Given this list of marker genes FUBP1 (far upstream element binding protein 1), KCNJ15, RSC1A1, SERPINA3, CCL4, GSR, ROR2, HSP90AB1 (heat shock protein 90 alpha family class B member 1, NCBI Gene Id 3326), CD38, LY6G6D, BTN3A3, CEP170B, KYAT1, ADAM19, BRSK2, ST3GAL5, VCAN, ANXA2, RPA3, EIF3B, CYP1B1, SOCS6, ALAS1, B3GNT2, CD14, PBX2 (PBX homeobox 2), PLXNC1, MNDA, OGA, TNFSF10, SPINK4, NUP153, NUP160, CXCR1, CTAG2, UBE2L6, USP10, SAMHD1, PSMC1, GLUL (NCBI Gene Id 2752), MSMO1, AKT2, LY6E, BCL2A1, PNP, DNAJC16, HSPA1A, ISG15, IFI44L, GLRX, SLC31A2, CPN1, CCT3, TRIM14, HOXC11, POLD2, TUBB2A, TRIP4, SLC7A7, ELAVL2, SEC23IP, MAX, KANK1, HSBP1, NEFH, POGZ, DHH, TDRD7, IFI44, CTDSP2, PIK3R4, BRCA2, SELE, LGALS9, C5orf15, F2, GAL, SETX, BBS9, ACSL1, OVOL3, SRSF3, CRLF3, MX1, ICE1, MX2, GCH1, IQSEC2, HSP90B1, FSCN1, C3AR1, COIL, ZWINT, IKBKE, BAZ1A, CHI3L1, PLEK, CCL8 (C-C motif chemokine ligand 8), MORF4L2, GRB2, RNASE4, ENDOD1, UBA7, COL13A1, CASP1, TOM1, MICB, RBM17, IL7R, TALDO1, SLC35D1, MMP8, ORAI2, SLCO1B1, DYNLL1, DLEC1, PSMA3, IRX3, CRAT, DLX2, IRF7, GSAP, RRM2, TLR1, DDX21, GNRH2, EFNB2, ITGAL, PYGM, OAS2 (2'-5'-oligoadenylate synthetase 2), CSRNP2, PTOV1-AS1, EMP1, MPZL1, MED14, SERPINB9 (NCBI Gene Id 5272), NCAPD2, PGAM1, HMGCS1, GART, FOS, HTRA1, GYG2, PARK7, PTPRCAP, CUL2, CD3D, CCL7, STAT2, S100A8, PRKCB, ATP2A2, CEACAM7 (CEA cell adhesion molecule 7), BRS3, PADI2, CYP7A1 (NCBI Gene Id 1581), ARR3, MUC6, PPID, EPB41L3, PSMA6, SEC14L1, TIMP3, BLVRA, S100A9, CGGBP1, AMHR2, NEDD8, ABI1, ATF5, CIR1 (corepressor interacting with RBPJ, CIR1), PIR, H2BC7, ALDH3B1, SKIL, SPTA1, CD27, COPG2IT1, SERPING1, IFIT2, FCGR3A, CDK3 (NCBI Gene Id 1018), OLFML2B, ALG8, SCGB1A1, SERPINB8, CCL2, CDH11, CD163, TRIM52, IFIT1, MYD88, OASL, AIM2 (NCBI Gene Id 9447), PPARD, ZNF45, CPT1B, LCP2, TXNIP, here is a description of the gene set: Genes down-regulated in comparison of dendritic cells (DC) exposed to L. donovani versus DCs exposed to M. tuberculosis. species: Homo sapiens from publication Chaussabel D, Semnani RT, McDowell MA, Sacks D, Sher A, Nutman TB (PMID 12663451) Monocyte-derived dendritic cells (DC) and macrophages (MΦ) generated in vitro from the same individual blood donors were exposed to five different pathogens, and gene expression profiles were assessed by microarray analysis. Responses to Mycobacterium tuberculosis and to phylogenetically distinct protozoan (Leishmania major, L. donovani, Toxoplasma gondii) and helminth (Brugia malayi) parasites were examined, each of which produces chronic infections in humans yet vary considerably in the nature of the immune responses they trigger. Human Gene Set: GSE360_L_DONOVANI_VS_M_TUBERCULOSIS_DC_DN